The following is a description of a gene set: Human Gene Set: HP_ENURESIS Enuresis studied in species Homo sapiens Lack of the ability to control the urinary bladder leading to involuntary urination at an age where control of the bladder should already be possible., and this is the list of marker genes: BMP1, AQP2, ZMYM2, FAM20A, KCNJ10, DLG3, ZMYM3, ELN, DPH2, RNF168, POLRMT, LRIG2, DMPK, SMARCA2, NPHP3, EBF3, AGXT, SLC25A13, AVPR2, PRKAR1B (protein kinase cAMP-dependent type I regulatory subunit beta), FOXP2, FOXP1, FA2H, RNF125, CLCNKB, MLXIPL, HPSE2, BNC2, KY, ITPR1, DPH1, SLC5A2, ADNP, SLC12A3